Given this list of marker genes EXOSC2, ZCCHC7, EXOSC10, EXOSC3, DIS3, here is a description of the gene set: The chemical reactions and pathways involving cryptic unstable transcripts (CUTs), which are transcribed from intergenic regions. Many intergenic regions are heavily transcribed, but the transcripts are rarely detected due to rapid degradation by the nuclear exosome. species: Homo sapiens Human Gene Set: GOBP_CUT_METABOLIC_PROCESS